Given this list of marker genes Socs3, Sumo1, Ifng, Ifngr1, Ifngr2, Ptpn2, Socs1, here is a description of the gene set: Reactome Pathway: Regulation of IFNG signaling electronically inferred by orthology from the curated human pathway This event has been computationally inferred from an event that has been demonstrated in another species.<p>The inference is based on the homology mapping from PANTHER. Briefly, reactions for which all involved PhysicalEntities (in input, output and catalyst) have a mapped orthologue/paralogue (for complexes at least 75% of components must have a mapping) are inferred to the other species. part of: Interferon gamma signaling studied in species Mus musculus